Given this list of marker genes NR4A3, CRLF2, NECTIN2, CD226, SPHK2, TSLP, HAVCR1, here is a description of the gene set: species: Homo sapiens Any process that activates or increases the frequency, rate, or extent of mast cell activation. Human Gene Set: GOBP_POSITIVE_REGULATION_OF_MAST_CELL_ACTIVATION